Given this list of marker genes EP300, CENPJ, CSH1, CSH2, HES5, NOTCH1, TYK2, CRLF3, TGFB1, IL5 (interleukin 5), CALM1, IL10RA, JAK2, IFNL1, OCIAD1, CRLF2, LEP, HES1, PIBF1, GHR, GH1, PTK6, TSLP, IL10RB, IL10, MGAT5, KIT, CCL5, IL6, PRLR, PRL, F2, GH2, OCIAD2, CSF2RA, WDR48, MIR221, IL26, CSHL1, NLK, ERBB4, F2R, ADIPOR1, IL7R, PTK2B, USP1, LIF, CAMK2A, CYP1B1, here is a description of the gene set: species: Homo sapiens Human Gene Set: GOBP_POSITIVE_REGULATION_OF_RECEPTOR_SIGNALING_PATHWAY_VIA_STAT Any process that activates or increases the frequency, rate or extent of receptor signaling pathway via STAT.